The following is a description of a gene set: The accumulation of DNA damage and mutations is considered a major cause of cancer and aging. While it is known that DNA damage can affect changes in gene expression, transcriptional regulation after DNA damage is poorly understood. We characterized the expression of genes in human primary fibroblasts after exposure to three different kinds of cellular stress that introduces DNA damage: 4-nitroquinoline-1-oxide (4NQO), gamma-irradiation, or UV-irradiation. Each type of stress elicited damage specific gene expression changes of up to 10-fold. A total of genes had similar changes in expression of 3-40-fold after all three kinds of stress. We examined transcription in cells from young and old individuals and from patients with Werner syndrome (WS), a segmental progeroid condition with a high incidence of cancer, and found various age-associated transcriptional changes depending upon the type of cellular stress. Compared to young individuals, both WS and old individuals had similarly aberrant transcriptional responses to gamma- and UV-irradiation, suggesting a role for Werner protein in stress-induced gene expression. Our results suggest that aberrant DNA damage-induced gene regulation may contribute to the aging process and the premature aging in WS. from publication Kyng KJ, May A, Stevnsner T, Becker KG, Kølvrå S, Bohr VA (PMID 15897889) Genes specifically responding to gamma radiation. studied in species Homo sapiens Human Gene Set: KYNG_DNA_DAMAGE_BY_GAMMA_RADIATION, and this is the list of marker genes: RIT2, MYB, NRP2, HELZ, AP1G1, HCLS1, SEC22A (SEC22 homolog A, vesicle trafficking protein), LINS1, ATP5MJ, VDAC3, HOXD9 (NCBI Gene Id 3235, homeobox D9), CACNA1I, LRBA, ATRX, CKS2, DOCK2, RBP4 (NCBI Gene Id 5950), DSC2, MITF, EPHA1, INSL4, LIPC, HBEGF, FRZB, ARNT, RAB2A, FOLH1, SYNC, RAB1B, APPBP2, DDX18, RNF168 (NCBI Gene Id 165918), SP3 (NCBI Gene Id 6670), PCSK5, BDH2, HSF2, FADS1, FBLN1, CYP39A1, RBM6, CRABP2, PRG2, SP140, RAB6A (RAB6A, member RAS oncogene family), ARF1, DCT, CCL13, CD8A, RHOB, AVPR1A, GBP1, MET, TIE1, NDEL1, MYO5B, SCD, SEMA3B, CIB2, PTGFRN, SMAD4, HLA-DQB1, PPP2CA, STAT5B, CHRNE, PDHA1, HIBADH, SLCO2A1, NRK, LDHC, TIA1, CYBB, PDE4DIP, PFN1 (NCBI Gene Id 5216), CHRNA7, PPIEL, TRAF6, CHL1